The following is a description of a gene set: species: Homo sapiens Human Gene Set: GOMF_QUATERNARY_AMMONIUM_GROUP_TRANSMEMBRANE_TRANSPORTER_ACTIVITY Enables the transfer of quaternary ammonium groups from one side of a membrane to the other. Quaternary ammonium groups are any compound that can be regarded as derived from ammonium hydroxide or an ammonium salt by replacement of all four hydrogen atoms of the NH4+ ion by organic groups., and this is the list of marker genes: SLC22A3, SLC44A4, SLC16A9, SLC22A4, SLC25A29, SLC22A5, SLC22A1, SLC25A19, SLC6A20, SLC22A16, SLC25A20, SLC22A2, SLC6A14, SLC22A15